The following is a description of a gene set: studied in species Mus musculus Mouse Gene Set: GOMF_ACTININ_BINDING Binding to actinin, any member of a family of proteins that crosslink F-actin., and this is the list of marker genes: Nrap, Myoz1, Synpo2, Csrp3, Pkd2, Pdlim5, Myot, Micall2, Hnrnpk, Pdlim3, Pdlim7, Kcna5, Pdlim1, Kcnn2, Lrrc10, Cacna1c, Xirp2, Dag1, Lmo7, Ldb3, Nfkb1, Rara, Csrp1, Trpc5, Alms1 (ALMS1, centrosome and basal body associated), Magi1, Pkd2l1, Prom1, Csrp2, Prickle4, Pdlim2, Nphs1, Rela, Pdlim4, Adora2a (NCBI Gene Id 11540), Mypn, Itgb1, Pparg, Ttn, Cacna1d, Trpc6, Ptprt